The following is a description of a gene set: studied in species Homo sapiens Human Gene Set: GOBP_POSITIVE_REGULATION_OF_CYTOPLASMIC_TRANSLATION Any process that activates or increases the frequency, rate or extent of cytoplasmic translation., and this is the list of marker genes: HNRNPD, YBX3, PIWIL2, DHX36, LIN28A, IGF2BP1, PABPC1, PKM, DHX9, PAIP1, SYNCRIP, CNBP (NCBI Gene Id 7555), ZCCHC13, EEF2, YBX1, CSDE1, HNRNPU